Given this list of marker genes PPARGC1A, EP300, TET3, BAZ1B, MYBBP1A, MED20, H2AC7, 18S rRNA, 5.8S rRNA, 28S rRNA, MED4, ZNF418, TAF1B, GTF2H5, KMT2D, ZNF264, SAP30BP, CDK5, AKAP8L, DNMT3B, GPAM, H2BC12L, SMARCC1, H2BC5, 5S rRNA, GPS2, MYO1C, MED27, MED6, DPF3, ZNF354A, PHF20, MCRS1, H2BC26 (NCBI Gene Id 128312), KMT2C (NCBI Gene Id 80260), H2BC4, BAZ2A, CDK8, SMARCE1, H2AC18, ATF7IP, H2AC14, H2BC1 (H2B clustered histone 1), ERCC6, KANSL3, GATAD2A, POLR1G, SIN3A, GATAD2B (NCBI Gene Id 57459), TTF1, ZNF708, PSIP1, ZZZ3, H2BC12, BCL7A, SMARCD3, SETD1B, MED31, POLR2L, ACSL1, CXXC1, TASP1, H2AZ2, CCNH, MNAT1, TADA3, PPHLN1, MED14, MTF2, H3C15, RB1, PHF1, SS18, H2BC14, SUV39H1 (SUV39H1 histone lysine methyltransferase), ZNF649, RBBP5, PNPLA2, RXRA, H2BC15, CBX3, ZNF257, EZH2, ZNF93, SF3B1, NCOA6, LIPE, MED24, POLR1H, TADA2A, ZNF816, ZNF141, SMARCD1, SIN3B, H2BC17, PHF19, SMARCD2, ERCC3, KAT14, EED, NCOR2, SMARCA5, ZNF680, ZNF224, ZNF331, SMARCA2, ZNF28, NCOA3, MPHOSPH8, NR5A2, ZNF30, PDK4, POLR2E, UBE2I, UHRF1, LPL, KMT2A (NCBI Gene Id 79951), TBL1XR1, ARID4B, ZNF610, H4C1, ZNF317, ELOVL5, MBIP, DPF1, DPF2, MED12, PLIN4, MED16, TET1, CHD3 (chromodomain helicase DNA binding protein 3), RBBP4, 45S pre-rRNA gene, GSK3B, SMARCB1, CBX5, TAF1D, DDX21, POLR1B, ZNF778, SS18L1, ZNF669, JARID2, H2AB1, TDG, HDAC1, PLIN2, DR1, SMARCA4, KAT2A (lysine acetyltransferase 2A), THRSP, MED10, H3-3A, SAP30L, SETD1A, 5.8S rRNA, TRIM28, LPIN1, ASH2L, KAT8, MTA3, PPARG, POLR1A, DEK, GTF2H2, H2AC4, C19orf84, ERCC2, ADIPOQ, KMT2B, HCFC2, TBL1X, TBP, ZNF273, MBD3, BCL7C, ANGPTL4, 28S rRNA, ABL1, PHF20L1, NCOR1, MGLL, ZNF324, AGPAT2, UBTF, ZNF320, POLR2K, PIWIL4, ZNF136, KANSL1, DNMT1, MORC2, OGT, ZNF765, ARID1B, ARID1A, EHMT1, PPARGC1B, ZNF454, POLR1C, CD36, POLR2F, TAF1A, TASOR, SAP18, POLR2H, DGAT2, SUMO2 (NCBI Gene Id 6613), H3C1, CDK7, WDR82, DPY30, SCD, CEBPA, KAT2B, ZNF425, MBD2, AEBP2, MEN1, BOD1, MED17, H2BC9, RBBP7, GTF2H1, SGF29, HDAC3, MED13, CHD4, MED30, ACSS3, TET2, SUZ12, HDAC2, RBM7, WDR5, ZNF33A, EZHIP, H2AJ, PAXIP1, MED1, SETDB1, ZNF534, DNMT3L, ZCCHC8, MTREX, GTF2H3, MTA2, H2BC3, FABP4, H2AC6, POLR1D, ZNF382, PEX11A, KDM6A, H2BC13, H2BC11, POLR1F, SIRT1, ZNF519, PHLDA1, RRP8, YEATS2, HCFC1, H2BC21, TAF1C, ZNF547, H2AX, MTA1, EHMT2, AJUBA, ACTL6A, CIDEC, NCOA1, H2AC20, SAP130, EZH1, BOD1L1, KANSL2 (KAT8 regulatory NSL complex subunit 2), SAP30, CREBBP, GTF2H4, MED7, EPOP, PLIN1, ACTB, NCOA2, SPOCD1, MED23, DNMT3A, SMARCC2, POLR1E, SCD5, BCL7B, SUDS3, CCNC, PAGR1, here is a description of the gene set: part of: Gene expression (Transcription) studied in species Homo sapiens Epigenetic processes regulate gene expression by modulating the frequency, rate, or extent of gene expression in a mitotically or meiotically heritable way that does not entail a change in the DNA sequence. Originally the definition applied only to heritability across generations but later also encompassed the heritable changes that occur during cellular differentiation within one organism.<br> Molecular analysis shows epigenetic changes comprise covalent modifications, such as methylation and acetylation, to DNA and histones. RNA interference has been implicated in the initiation of some epigenetic changes, for example transcriptional silencing of transposons. Proteins which bind to the modified DNA and histones are then responsible for repressing transcription and for maintaining the epigenetic modifications during cell division.<br>During differentiation, patterns of gene expression are established by polycomb complexes PRC1 and PRC2. PRC2 methylates histones and DNA to produce the initial marks of repression: trimethylated lysine-27 on histone H3 (H3K27me3) and 5-methylcytosine in DNA. PRC2, through its component EZH2 or, in some complexes, EZH1 trimethylates lysine-27 of histone H3. The H3K27me3 produced by PRC2 is bound by the Polycomb subunit of PRC1. PRC1 ubiquitinates histone H2A and maintains repression.<br>PRC2 and other epigenetic systems modulate gene expression through DNA methyation, the transfer of a methyl group from S-adenosylmethionine to the 5 position of cytosine in DNA by a family of DNA methyltransferases (DNMTs): DNMT1, DNMT3A, and DNMT3B.<br>In the reverse process TET1,2,3 and TDG demethylate DNA through the oxidation of the methyl group of 5-methylcytosine by TET enzymes and the excision of the oxidized product (5-formylcytosine or 5-carboxylcytosine) by TDG.<br>Ribosomal RNA (rRNA) genes are activated and deactivated according to the metabolic requirements of the cell. Positive epigenetic regulation of rRNA expression occurs through chromatin modifications produced by activators such as ERCC6 (CSB), the B-WICH complex, and histone acetylases such as KAT2B (PCAF). Negative epigenetic regulation of rRNA expression occurs through chromatin modifications produced by repressors such as the eNoSC complex, SIRT1, and the NoRC complex.<br><br>WDR5 is a component of six histone methyltransferases and three histone acetyltransferases involved in epigenetic regulation of gene expression.<br><br>Endogenous retroelements are transposable elements that transpose to new genomic locations via an RNA intermediate and reverse transcription. Retroelements are silenced epigenetically in the human genome by mechanisms that include PIWI-interacting small RNAs (piRNAs) that transcriptionally silence retroelements through an RNA interference mechanism, KRAB-ZFP zinc finger-type repressors that bind specific DNA sequences in retroelements, and the HUSH complex that recognizes retroelements through nascent RNA or through existing histone H3 lysine-9 trimethylation. Reactome Pathway: Epigenetic regulation of gene expression